Given this list of marker genes CFL1, CD3E, RRAS, FERMT2, EMP2, SDC4, EPB41L5, SFRP1, TSC1, POLDIP2, CIB1, CEACAM6, MAP4K4, MYOC, CD36, CX3CL1, EPHA1, FUT1, DISC1, RIN2 (Ras and Rab interactor 2), LEF1, GFUS, SMAD3, EFEMP2, COL16A1, VEGFA, CCL28, CSF1, PTK2B, TEK, ROCK1 (Rho associated coiled-coil containing protein kinase 1), JUP, ABL1, CDH13, PLEKHA2, PTPRJ, FERMT1, CCR7, S100A10, UTRN (utrophin), RAC1, NRP1, DAG1, LIMS1, CDK6, ITGB3, ITGB1BP1, PPM1F, GSK3B, PLPP3, CCL25, THY1, HRG, KDR, SKAP1, WNT4, CCL21, here is a description of the gene set: studied in species Homo sapiens Human Gene Set: GOBP_POSITIVE_REGULATION_OF_CELL_MATRIX_ADHESION Any process that activates or increases the rate or extent of cell adhesion to an extracellular matrix.